Given this list of marker genes ATF6, BLVRA, SLC19A1, BUD31 (NCBI Gene Id 8896), NCAPD3, ATP5MF, FAF1, SRR, SMC6, USP18, TOE1, ISG15, PRIM1, ARL4A, MFN2, CYREN, SP110, NABP2, IFITM3, MRPS14, XRCC6, DNTTIP2, LSM4, NDUFS6, CDC23, DDX49, SPC25, NOC3L, RFC5, URB2, NBN, GOLT1B, PPP6C, INPP4B, LSM2, CFAP298, FANCL, ITGB3BP, IER3IP1, NUP88, TEX261, PWP1, KIF18A, HDDC2, OAS3, BMAL2, ALG8, PSMB10, ZNF207, DDX19A, JOSD1 (Josephin domain containing 1), SMC2, SOAT1, KIF18B, SLC35G2, YWHAE, MX1, PPP2R1B, RCC1L, KIFC1, YBX1 (Y-box binding protein 1), PSMD13, RANGAP1, DBF4, PSMC6, PQBP1, PRKAG1, ACAT1, LSM3, IFT46 (intraflagellar transport 46), MLH1, SLC25A46, FASTKD2, AIMP1, SLC25A11, METAP2, SAMD9, CFAP20, EMG1, LSM5 (NCBI Gene Id 95999), FASTKD1, NVL, IFI27, GOT2, RUSC1, HSPA8, ENOPH1, MRPL57, PITPNB, FUT4 (fucosyltransferase 4), SLC52A2, ATAD2 (ATPase family AAA domain containing 2), C3orf52, DCAF17, TTC27, SRBD1, MOB4, CSNK2A1, VBP1, RPP30, FOSL1, NOL11, RAC1, GTF2F2, COX8A, U2AF1, MMADHC, LAPTM4B, USP10, EIF4G2, SRSF2, TSR1, HSBP1, GMFB, PSMA7, LMNB1, NASP, IFITM1, HNRNPR, HCFC1, ARK2N, KIF4A (NCBI Gene Id 55595), AFG3L2, HACD3, PSMC2 (proteasome 26S subunit, ATPase 2, NCBI Gene Id 5701), ABCF1, PPAT (phosphoribosyl pyrophosphate amidotransferase), GTPBP4, APOOL, MCMBP, SRPRA, CCDC85B, IFT56, CPOX, SLC25A44, NAT10, TRIM21, CYC1, EIPR1, PRPF19, NFIL3, MTCH2, CIAO1, LANCL2, RAD23A (NCBI Gene Id 5886), ANAPC10, ATF4, PDXK, SLC22A2, NDUFA6, NUDC, SMC4, TMEM11, EMC1, BAG4, CISD1, THOC5, RFWD3, GRSF1, MIF, BNIP1, RAD23B, PDIA4, RARS1, H2AZ1, CDC5L, ISG20, MNAT1, PMPCA, SUMO4, NCDN, SS18L2, RTP4, CTNNAL1, CASP7, PSMC3, DESI2, CIT, IGFBP4, NGDN, DHRS11, PPAN, MTPAP, DNAAF2, FKBP11, NR2C2, CSTF1, DDRGK1, HMGB3, COX17, INVS, NELFE, PSMD6, APOL6, UQCRQ, MRPL34, PSAT1, CALU, HIRIP3, NDUFB6, here is a description of the gene set: Genes down-regulated in CD11b BoneMarrow from BALBc mouse incubated with GMCSF and IL-6 versus CD11b BoneMarrow from BALBc mouse incubated with GMCSF and GCSF. from publication Marigo I, Bosio E, Solito S, Mesa C, Fernandez A, Dolcetti L, Ugel S, Sonda N, Bicciato S, Falisi E, Calabrese F, Basso G, Zanovello P, Cozzi E, Mandruzzato S, Bronte V (PMID 20605485) studied in species Homo sapiens Human Gene Set: GSE21927_GMCSF_IL6_VS_GMCSF_GCSF_TREATED_BONE_MARROW_DN Tumor growth is associated with a profound alteration of myelopoiesis, leading to recruitment of immunosuppressive cells known as myeloid-derived suppressor cells (MDSCs). Analyzing the cytokines affecting myelo-monocytic differentiation produced by various experimental tumors, we found that GM-CSF, G-CSF, and IL-6 allowed a rapid generation of MDSCs from precursors present in mouse and human bone marrow (BM). BM-MDSCs induced by GM-CSF+IL-6 possessed the highest tolerogenic activity, as revealed by the ability to impair the priming of IFN- -producing CD8+ T cells upon in vivo adoptive transfer. Moreover, adoptive transfer of syngeneic, GM-CSF+IL-6-conditioned MDSCs to diabetic mice transplanted with allogeneic pancreatic islets resulted in long term acceptance of the allograft and correction of the diabetic status. Cytokines inducing MDSCs acted on a common molecular pathway. Immunoregulatory activity of both tumor-induced and BM-derived MDSCs was entirely dependent on C/EBP transcription factor, a key component of the emergency myelopoiesis triggered by stress and inflammation. Adoptive transfer of tumor antigen-specific CD8+ T lymphocytes resulted in therapy of established tumors only in mice lacking C/EBP in myeloid compartment. These data unveil another link between inflammation and cancer and identify a novel molecular target to control tumor-induced immune suppression. We used gene expression analysis to identify those factors, secreted by tumor-infiltrating MDSC, which could drive emathopoiesis. Moreover we compare gene expression profile of tumor-induced MDSC, obtained from either the spleen and the tumor infiltrate of tumor bearing mice, and in vitro bone marrow-derived MDSC.